Given this list of marker genes IL6R, CYBC1, IL1RN, G6PC3, IL17RA, VANGL1, MPEG1, IGHM, UBE2A, MAX, PKHD1, FGFR3, PGM3, ABCB4, PSTPIP1, ENPP1, TGFB1, CYBB, PI4KA, PALB2, IGKC, IKBKB, PSENEN, ACVRL1, OTULIN, RAC2, PSEN1, CDKN2A, SRP68, SMAD4, PTPN6, IL10RB, PHEX, IGHG2, MEFV, ITGB2, CTSC, ELF4, ELANE, BLM, IKZF3, BRCA2, MNX1, KRAS, DLX3, DMP1, IL6ST, LCK, PALLD, WDR1, CLCN7, XIAP, NCF2, BRCA1, PDCD1, MYD88, IL10RA, TP53, ENG, DDR2, B2M, IRAK4, NCF4, RIPK1, NCF1, TTC7A, DOCK8, GJB2, STAT3, NTRK1, SEC61A1, FGF23, GJB6 (NCBI Gene Id 1897), ZNF341, RABL3, CYBA, LCP2, BTK, CARMIL2, here is a description of the gene set: An abscess is a localized collection of purulent material surrounded by inflammation and granulation. Abscess species: Homo sapiens Human Gene Set: HP_ABSCESS